Given this list of marker genes MAPK1, BAX, CDK5, IRS1, EP300, RPS6KA3, EGR1, RALGDS (NCBI Gene Id 95849), REST, PTPN11, FOSB, NTRK3, AP2A1, GRB2, FRS3, PCSK6, EGR3 (NCBI Gene Id 1960), DUSP7, JUND, JUNB, ASCL1, FYN, TPH1, IRS2, PTPRO, ADORA2A, PTPRS, MAPKAPK2, PPP2R5D, CDK5R1, PCSK5, RPS6KA1, EGR4, DUSP3, SGK1, AP2S1 (NCBI Gene Id 9161), F3, BRAF, MAP2K2, SH3GL3, ADCYAP1, MAPK3, CREB1, ID1, ARC, PIK3CA, ADCYAP1R1, NAB1, RAC1, SOS1, SHC2, STAT3, MAPK13, LYL1, MEF2A (NCBI Gene Id 4205), VRK3, MAPK14, SHC1, EGR2, RHOA, KIDINS220, NELFB (negative elongation factor complex member B), KRAS, FOS, CLTA, DNM3, MAP2K1, PPP2CA, GAB1, DUSP4, PPP2CB, ATF2, PIK3R2, MEF2D, RAP1A, MAPK12, NRAS, RPS6KA2, NTRK1, NTRK2, TCF12, AP2M1, CRKL, DUSP6, FURIN, ID4, PIK3R1, CRK, ID3, ATF1, SRF, RIT1, CLTC, RALA, RRAD, PPP2R1A, DOCK3, MAPKAPK3, HRAS, AP2B1, DNM2, DNM1, MAP2K5, RPS6KA5, SH3GL2, NTF4, MAPK7, VGF, TRIB1 (tribbles pseudokinase 1), ID2, FOSL1, TIAM1, SHC3, NAB2, MAPK11, ELK1, PPP2R1B, RAPGEF1, MEF2C, PIK3CB, GRIN2B, YWHAB, AP2A2, CDK5R2, CHD4, FRS2, DNAL4, NTF3, RALB, RIT2, PLCG1, SRC, BDNF, NGF, here is a description of the gene set: Neurotrophins (NGF, BDNF, NTF3 and NTF4) play pivotal roles in survival, differentiation, and plasticity of neurons in the peripheral and central nervous system. They are produced, and secreted in minute amounts, by a variety of tissues. They signal through two types of receptors: NTRK (TRK) tyrosine kinase receptors (TRKA, TRKB, TRKC), which differ in their preferred neurotrophin ligand, and p75NTR death receptor, which interacts with all neurotrophins. Besides the nervous system, TRK receptors and p75NTR are expressed in a variety of other tissues. For review, please refer to Bibel and Barde 2000, Poo 2001, Lu et al. 2005, Skaper 2012, Park and Poo 2013.<p>NTRK receptors, NTRK1 (TRKA), NTRK2 (TRKB) and NTRK3 (TRKC) are receptor tyrosine kinases activated by ligand binding to their extracellular domain. Ligand binding induces receptor dimerization, followed by trans-autophosphorylation of dimerized receptors on conserved tyrosine residues in the cytoplasmic region. Phosphorylated tyrosines in the intracellular domain of the receptor serve as docking sites for adapter proteins, triggering downstream signaling cascades.<p>NTRK1 (TRKA) is the receptor for the nerve growth factor (NGF). NGF is primarily secreted by tissues that are innervated by sensory and sympathetic neurons. NTRK1 signaling promotes growth and survival of neurons during embryonic development and maintenance of neuronal cell integrity in adulthood.<p>Brain-derived neurotrophic factor (BDNF) and neurotrophin-4 (NTF4, also known as NT-4) are two high affinity ligands for NTRK2 (TRKB). Neurotrophin-3 (NTF3, also known as NT-3) binds to NTRK2 with low affinity and may not be a physiologically relevant ligand. Nerve growth factor (NGF), a high affinity ligand for NTRK1, does not interact with NTRK2. NTRK2 signaling is implicated in neuronal development in both the peripheral (PNS) and central nervous system (CNS) and may play a role in long-term potentiation (LTP) and learning. NTRK2 may modify neuronal excitability and synaptic transmission by directly phosphorylating voltage gated channels.<p>NTF3 (NT-3) is the ligand for NTRK3 (TRKC). Signaling downstream of activated NTRK3, regulates cell survival, proliferation and motility. In the absence of its ligand, NTRK3 functions as a dependence receptor and triggers BAX and CASP9-dependent cell death. part of: Signaling by Receptor Tyrosine Kinases Reactome Pathway: Signaling by NTRKs studied in species Homo sapiens